The following is a description of a gene set: studied in species Homo sapiens Human Gene Set: GOBP_POSITIVE_REGULATION_OF_LYMPHOCYTE_DIFFERENTIATION Any process that activates or increases the frequency, rate or extent of lymphocyte differentiation., and this is the list of marker genes: PTPRC, WNT10B, BTN2A2, TESPA1, GAS6, KAT5, ACTL6A, AP3B1, FOXO3 (NCBI Gene Id 2309), ADAM8, IL2, HLX, TGFBR2, RASGRP1, SOX13, RHOH, OPA1, SOX4, RAG1, HLA-DRB1, SMARCC1, CR1, IL2RA, ARID1A, ACTB (NCBI Gene Id 60), AMBRA1, CD83, STAT5B, IL12B, PBRM1, SMARCA2, TGFB1, TNFSF9, GATA3, IL12RB1 (NCBI Gene Id 3594), GPR65, CD27, IL23R, ZBTB16, ZBTB1, NCKAP1L, CD80, IL1RL2, SOCS5, LEF1, SMARCD1, IL15RA, PRKCZ, CD74 (NCBI Gene Id 972), LILRB2, SOX12, SHH, ACTL6B, EP300, CD46, INPP5D, IL7R, SART1, PCK1, CYLD, AXL, PNP, ARID2, VSIR, RARA, EGR3, SASH3, SYK, XRCC6, PCID2, TNFSF4, IHH, PHF10, ZMIZ1, IL4R, ZBTB7B, RIPK2, NFKBIZ, ANXA1, SMARCB1, SMARCD2, LGALS9, HLA-G, ITPKB, IL18, STAT5A, IL2RG, IL15, ADA, GLI2, LILRB4, DUSP10, GLI3, NKAP, IL10, BRD4, IL23A, BCL6, KLHL25, NFKBID, XBP1, BRD2, ARID1B, CBFB, SHB, VNN1, SMARCA4, PRKDC, IL4, CD86, RUNX3, FOXP3, MDK, LCK, SMARCC2 (SWI/SNF related, matrix associated, actin dependent regulator of chromatin subfamily c member 2), IL4I1, IL21, BTK, PPP2R3C, CCL19, IFNG, IL36B, AP3D1, MIR21, BAD, ZAP70, DDRGK1, TOX, MALT1, HLA-DRA, IL7, RUNX1, SPI1, BRD7, RHOA, PIK3R6, SMARCE1, MMP14, SOCS1, NLRP3, SMARCD3